The following is a description of a gene set: This event has been computationally inferred from an event that has been demonstrated in another species.<p>The inference is based on the homology mapping from PANTHER. Briefly, reactions for which all involved PhysicalEntities (in input, output and catalyst) have a mapped orthologue/paralogue (for complexes at least 75% of components must have a mapping) are inferred to the other species. Reactome Pathway: Glycogen synthesis part of: Glycogen metabolism electronically inferred by orthology from the curated human pathway species: Mus musculus, and this is the list of marker genes: Gbe1, Ugp2